Given this list of marker genes RDX, DLX6-AS1, BTG1, SCGN, DLX5, PDZRN3 (PDZ domain containing ring finger 3), PRKCA, here is a description of the gene set: Human Gene Set: ZHONG_PFC_C1_DLX5_POS_INTERNEURON studied in species Homo sapiens from publication Zhong S, Zhang S, Fan X, Wu Q, Yan L, Dong J, Zhang H, Li L, Sun L, Pan N, Xu X, Tang F, Zhang J, Qiao J, Wang X (PMID 29539641)